The following is a description of a gene set: Estrogen-stimulated signaling through PRKCZ Human Gene Set: REACTOME_ESTROGEN_STIMULATED_SIGNALING_THROUGH_PRKCZ species: Homo sapiens, and this is the list of marker genes: PRKCZ, PDPK1, NRAS, MAPK1, KRAS, HRAS